The following is a description of a gene set: The specialization of the spermatid nucleus during the development of a spermatid into a mature male gamete competent for fertilization. species: Homo sapiens Human Gene Set: GOBP_SPERMATID_NUCLEUS_DIFFERENTIATION, and this is the list of marker genes: SYCP3, DMRTC2 (DMRT like family C2), TMF1, FSHR, MFSD14A, KAT5, KDM3A, NECTIN2, RNF8, AGFG2, SYCP1, SRPK1, PSME4, PRM1, TNP1 (transition protein 1), H1-7, PIWIL1, EPC1, PYGO1, BRDT, SELENOF, TBPL1, H2BC1, TSSK6, CCER1, AGFG1, TNP2, PYGO2, HMGB2, CHD5 (chromodomain helicase DNA binding protein 5)